The following is a description of a gene set: Any process that results in a change in state or activity of a cell (in terms of movement, secretion, enzyme production, gene expression, etc.) as a result of a stimulus indicating an increase or decrease in the concentration of salt (particularly but not exclusively sodium and chloride ions) in the environment. Mouse Gene Set: GOBP_CELLULAR_RESPONSE_TO_SALT_STRESS studied in species Mus musculus, and this is the list of marker genes: Mir29b-2, Xrcc5, Mir29b-1, Xrcc6, Trpv4, Zfp36l1, Mir99a, Mir30b, Abcb1a, Capn3, Mir7b, Mir137, Mir9-2, Mir451a, Mir9-3, Mir9-1 (NCBI Gene Id 387133), Slc25a23, Mir100, Pck1, Fbp1, Mir204, Slc12a6, Akr1b1, Mir434, Micu1, Aqp1, Mir29c, Letm1, Efhd1